The following is a description of a gene set: Mouse Gene Set: GRAESSMANN_APOPTOSIS_BY_SERUM_DEPRIVATION_DN studied in species Mus musculus from publication Graessmann M, Berg B, Fuchs B, Klein A, Graessmann A (PMID 17160024) Genes down-regulated in ME-A cells (breast cancer) undergoing apoptosis upon serum starvation (5% to 0% FCS) for 22 hr. Impairment of the complex regulatory network of cell death and survival is frequently the reason for therapy resistance of breast cancer cells and a major cause of tumor progression. We established two independent cell lines from a fast growing mouse breast tumor (WAP-SVT/t transgenic animal). Cells from one line (ME-A cells) are sensitive to apoptotic stimuli such as growth factor depletion or treatment with antitumor agents (e.g. doxorubicin). Cells from the second line (ME-C cells), which carry a missense mutation at the p53 codon 242, are very insensitive to apoptotic stimuli. Co-cultivation experiments revealed that the ME-C cells mediate cell death resistance to the ME-A cells. Microarray and Western blot analysis showed that osteopontin (OPN) is selectively overexpressed by the ME-C cells. This glycoprotein is the most abundant protein secreted by the ME-C cells and we obtained strong indications that OPN is the main antiapoptotic factor. However, the OPN containing ME-C cell medium does not alter the expression level of pro- or antiapoptotic genes or known inhibitors of apoptosis (IAPs). Its signaling involves mitogen-activated protein kinase (MAPK)/extracellular signal-regulated kinase (ERK) kinase (MEK)1/2 as the kinase inhibitor PD98059 restores apoptosis but not the Akt inhibitor. In the ME-A cells, mitochondrial cytochrome c release occurs with and without external apoptotic stimuli. OPN containing ME-C cell medium does not prevent the mitochondrial cytochrome c release and caspase-9 processing. In serum starved ME-A cells, the OPN containing ME-C cell medium prevents caspase-3 activation. However, in doxorubicin-treated cells, although apoptosis is blocked, it does not inhibit caspase-3. This indicates that the ME-A cells distinguish between the initial apoptotic stimuli and that the cells possess a further uncharacterized control element acting downstream from caspase-3., and this is the list of marker genes: Selenow, Foxh1, Ppp1r3c, Jmy, Per2, Casp6, Nos3, Cdh5, Mt2, Hoxa1, Polr3k, Cyb561, Ubxn2a, Txnl1, Porcn, Gata2, Klk9, Doc2g, P4ha2, Mrpl48, Lck, Tenm4, Cacna1g, Eif2ak3, Dusp1, Isg20, Spata13, Anp32a, Zbtb16, Mal (NCBI Gene Id 17153), Rabgap1l, Trap1, Deptor (NCBI Gene Id 97998), Nos2, Lpin1, Klk1b22, Mical1, Rab27b, Abcd4, Borcs7, Map1b, Jarid2, Odf2, Id2, Pdlim7, Pdk1, Slc25a29, Septin5, Lhpp, Osbpl6, Pcolce (NCBI Gene Id 18542), Piga, Cyp24a1, Capg, Cry2, Serpinb1a, Srxn1, Hps1, Dnm1, Mapk8ip3, Bag2, Rab2a, Bag5, Emc4, Sh3kbp1, Tnfrsf1b, Elac1, Zfp385a, S100a16, Mybl1, Ndrg1, Egln1, Car9, Stc1, Fam162a, Fbxo21, Apobr, Usp43, Abhd6, Tamalin, Dusp9, Armc5, Zbtb46, Eral1, Cnn1, Plekha2, Cav3, Pdxk, St6galnac4, Rem2, Bcl2l2, Papola, Gsta2, Csdc2, Tacc3 (transforming, acidic coiled-coil containing protein 3), Adamts15, Thsd1, Txndc11, Mcam, Nasp, Ero1a, Jun, Jag2, Kcnj14, Gys1, Tpd52, Krt14, Gbe1, Edn2, Inpp5a, Nphp1, Omp, Cdc37, Wipf1, Flt3l, Hspb8, Alx3, Rsph6a, Car12, Man2b2, Vcam1, Ass1, Gpr35, Metrn, Hilpda, Pgm2, Pdia5, Card19, Noxo1, Abtb1, Homer1, Elmo2, Gclc, Epb41l4b, Hid1, Nin, Hyal1, Galk1, Fam118a, Kif2a, Dgat2, Bcl11a, Efhd2, Sccpdh, Hes6, Fcrla, Rapgef3, Bin3, Polr1has, Hikeshi, Gpr146, Copb2, Abhd18, Gcnt2, Tha1, Czib, Zfp101, Efhd1, Tmem191, Crocc, Cep70, Pigu, Rab3d, Cog1, Serpine1, Il15ra, Gzma, Prkca, Map1lc3a, Pkp2, Myorg, Atp13a2, Khk, Kdelr3, Tm7sf3, Elf5, Cndp2, Kcnh2, Spdef, Dgcr6 (DiGeorge syndrome critical region gene 6), Naaa, Tpm3, Angptl2, Ehd1, Slc66a2, Gp1bb, Slc5a9, Cdr2 (NCBI Gene Id 12585), Plagl2, Slc1a4, Hmox1, Cbx8, Med24, Cldn3 (NCBI Gene Id 12739, claudin 3), Klf9, Kif1a, Naa80, Capn5, Paxip1, Dnajc18, Krtap19-1, Lgals4, Atxn7, Ric8a, Wap (NCBI Gene Id 22373, whey acidic protein), Eno2, Vegfa, Ralgps1 (Ral GEF with PH domain and SH3 binding motif 1), Pvr, Mphosph6, Masp1, Tes, Ppfia4, F3, Gpd1, Abca2, Tbl2, Rgs11, Thrsp, Pfn2, Pkp1, Pigq (NCBI Gene Id 23889), Nisch, Ndrg4, Proc, 1190005I06Rik, Higd1a, Ano10, Eno3, Cldn9, Mpp2, Crhr2, Tmcc2, Bnip3, Slc2a1, As3mt, Mus81, Stk10, Tgm2